Given this list of marker genes AMY1C, AMY2A, MGAM, AMY1B, AMY2B, AMY1A, here is a description of the gene set: Catalysis of the hydrolysis of amylose or an amylose derivative. Human Gene Set: GOMF_AMYLASE_ACTIVITY species: Homo sapiens